Given this list of marker genes Rps15, Msx1, Acer2, Casp6, Rps7, Casp2, Ifi213, Dyrk1a, Atrx (ATRX, chromatin remodeler), Rffl, Npm1, Rpf2, Nop53, Trim24, Paxip1, Ifi209, Rrm2b, Ep300, Snw1, Wwox, Usp10, Cd74, Chd5, Rbm38, E2f2, Mdm2, Tifab, Usp28, Sox4 (NCBI Gene Id 20677), Hnrnpk, Mybbp1a, Cdkn1a, Chek2, Ifi208, Bcl3, Hapstr1, Bcl2l12 (NCBI Gene Id 75736), Armc10, Spred2, Bax, Eef1e1, Uri1, Rnf34, Aen, Trp73, Hipk1, Cdip1, Zfp385a, Atm, Pycard, Brca2, Pml, Sh3glb1, Ifi203-ps, Ell3, Stk11, Znhit1, Tmem109, Hic1 (hypermethylated in cancer 1), Triap1, Mndal, Trp53, Mif, E2f1, Rps6ka6, Mlf1, Bok, Morn3, Dyrk3, Topors, Ifi206, Ddit4, Ndrg1, Perp, Sp100, Eda2r (NCBI Gene Id 279598), Rps20, Cdkn2a, Ifi214, Ing4, Ankrd2, Dyrk2, Rrp8, Ifi211, Psmd10, Rpl26, Snai1, Hint1, Sirt1 (sirtuin 1), Rpl37, Foxm1 (forkhead box M1), Myo6, Pmaip1, Yju2, Twist1, Pdk2, Fhit, Ppp2r5c, Sesn2, Pou4f2, Cd44, Trp63, Nop2, Pidd1, Ppm1d, Grem1, Pak1ip1, Ifi205, Ubb, Cops3, Mdm4, Rrn3, Rpl23, Cep63, Phlda3, Rpl11, Aars1, Atad5, Hipk4, Pcbp4 (poly(rC) binding protein 4), Bdkrb2, Marchf7, Foxo3, Hipk2, Muc1, Rpl5, Jmy, Cdk5rap3, Hexim1, Myc, Bmyc, Ndufs6, Ercc2, Zmpste24, Usp15, Ifi204, Zfp385b, Smyd2, Kat5, Cradd, Rps27l, Bag6, Prap1, Ifi207, Pou4f1, Nupr1, Ifi203, Kmt5a, Snai2, E2f7, Prmt6, Ankrd1, Msh2, Spred1, Prkn, Rpl37rt, Tfap4, Atr, Rrs1, Ppp1r13b, Ddx5, Knl1, Bop1, Batf, Trp53bp2, Pla2r1, Kdm1a, Shisa5, Ptprv, Bbc3, Steap3, Ppp1r15a, Kdm8, Pttg1ip, here is a description of the gene set: Mouse Gene Set: GOBP_SIGNAL_TRANSDUCTION_BY_P53_CLASS_MEDIATOR An intracellular signaling process that is induced by the cell cycle regulator phosphoprotein p53 or an equivalent protein. studied in species Mus musculus